The following is a description of a gene set: Human Gene Set: HP_ABNORMALITY_OF_CIRCULATING_GLUCOCORTICOID_LEVEL Abnormality of circulating glucocorticoid level studied in species Homo sapiens An abnormality of the concentration of a glucocorticoid in the blood., and this is the list of marker genes: USP48, CDKN2B, TERT, PIK3CA, PDGFB, TXNRD2, USP8, POR, NFKB2, SUFU, NR0B1, CDKN2C, CBX2, PDE11A, CDH23, PCSK1 (NCBI Gene Id 5122), CDKN1B, RET, MPV17, GATB, PRNP, SMARCE1, HSD11B1, ATRX, PDE8B, KDM1A, MRAP, KCNJ11, AKT1, TBX19, HSD11B2, STAR, TP53, CYP21A2, ROBO1, PRKACA, SMO, NR3C1, ABCD1 (NCBI Gene Id 215), GMPPA, HTR1A, QRSL1, CDKN1A, CYP11B2, GLI3, POMC, CYP11B1, MYT1L, TRAF7, NF2, PRKAR1A, TRAPPC11 (trafficking protein particle complex subunit 11), SERPINA6, BAP1, AAAS, GATC, ARMC5, CDKN2A, MEN1, GNAS, HSD3B2, CYP11A1, CTNNB1, SMARCB1, ZNRF3, NNT, CYP17A1, MC2R, BRAF, AIRE, CYB5A